Given this list of marker genes RBCK1, ZNF395, RTL8C, ZC3H12B, LRP6, C3P1, NTN5, CASP10, LINC01193, NAA16, DYNC2LI1, MYO9A, HAND1, ZNF512B, PREB, INPP4A, STX3, RAB24, SMOC1 (NCBI Gene Id 64093), ZC3H6, LINC01098 (NCBI Gene Id 285501), VPS13C, ZNF879, MRPL24, NEXN, MCFD2, ST6GALNAC4, MROH1, TNIP3, PAAF1, HERC2, CTSF, NUP35, C11orf71, ERMARD, HOXB9, SLC39A10, WDR77, ZNF512, GFOD3P, TMEM71, C1orf174, PPID, SMAGP, SLC37A4, TATDN2, FTL (ferritin light chain), LIG1, NBEA, METTL15, AKR1A1, PMS2P1, ZNF844, ACY1, ENSG00000284634 (novel transcript), FAM216A, ZNF688, SPPL2B, NUMB, TRIM56, FRRS1L, KLHL32, PLCL1, SNX27, LAPTM4B, BSCL2, PRDM10, AFG2A, BTN3A1, LINC01550, PNPLA7, ANKS1A, PBLD, PC, SLC35F6, FAM13C, CREBRF, LIPT1, NFKBIL1, GRK7, AIF1, CFAP418, ZNF134, WDR3, DCHS1, MTA3, PHF7, PDE7B-AS1, LEF1-AS1, CRP, EEF2KMT, LAS1L, LEPROT, ZNF141, FAM120C, DRAM2, CRYGN, TSC1, SERINC5, TRABD2A, OXNAD1, MRNIP, MPP1, FAHD2A, UBAC2, FOXN3, PEF1, SSBP2, KIFAP3, CSKMT, KCNA6, TNFRSF10D, CCR7, PDIA5, TBP, DOLK, GPRASP3, ZNF582, RAB3A, YTHDC2, TRPV1, PTK2, PRRC2B, IDNK, ZSCAN18, ZFP36L1, PARP16, MED30, ZBTB44, ZNF436, PPFIBP2, APEX1, ZNF658, NR2C2, PHYH, RFX5, SLC26A4-AS1, FHAD1, ZNF660, ALS2CL, ACTN1, ZNF232, NOSIP, MRPS9, MDS2, RYK, PDZD9, GLB1L, NET1, MYB, ATP10A, ZSCAN25, PEX12 (peroxisomal biogenesis factor 12), RGL2 (ral guanine nucleotide dissociation stimulator like 2), KDM4C, C1QTNF3, SETD6, HSF2, TTC32, BCDIN3D, ITPKB, SLC35E3, CRTC3, RMI1, POP5, SPAG5-AS1, SETDB1, ZNF362, ARMCX2, RAB30, SNHG3, EIF1AX, RWDD2A, HTN3, ZNF706 (zinc finger protein 706), PEX11B, CDNF, RNF157, PIK3R2, TTC28, RHOBTB3, ADGRA3, ORMDL1, CNKSR2, LANCL1, CBX7, IKZF1, MFSD8, TAPT1, LAMC2, DPEP2, ACVR1C, here is a description of the gene set: Human Gene Set: GSE26928_NAIVE_VS_CENT_MEMORY_CD4_TCELL_UP Genes up-regulated in comparison of naive CD4 T cells versus CD4 central memory T cells. from publication Chevalier N, Jarrossay D, Ho E, Avery DT, Ma CS, Yu D, Sallusto F, Tangye SG, Mackay CR (PMID 21471443) species: Homo sapiens